The following is a description of a gene set: Human Gene Set: KEGG_MEDICUS_REFERENCE_SPINDLE_ASSEMBLY_CHECKPOINT_SIGNALING Spindle assembly checkpoint signaling. Pathway ID: N00493. Pathway type: Reference. Pathway class: nt06230 Cell cycle. Pathway Definition from KEGG: MAD1L1 -> (MAD2L1/2+BUB1B+BUB3) -| (ANAPC+CDC20) -| PTTG -| ESPL1 species: Homo sapiens, and this is the list of marker genes: ANAPC2, CDC27, PTTG2, PTTG1, CDC23, ANAPC11, CDC26, ESPL1, ANAPC7, BUB1B, BUB3, ANAPC1, CDC20, CDC16, MAD2L2, MAD2L1, MAD1L1, ANAPC10, ANAPC4, ANAPC5, ANAPC13